The following is a description of a gene set: species: Mus musculus from publication Chen Y, Wang X (PMID 31504780) Mouse Gene Set: MIR_3102_5P Genes predicted to be targets of miRBase v22 microRNA mmu_miR_3102_5p in miRDB v6.0 with MirTarget v4 prediction scores > 80 (high confidence targets)., and this is the list of marker genes: Heph, Car7, Tmpo, Erv3, Frmd7, Tcf12, Slc2a1, Tcte2, Rbm39, Camta1, Hrh4, C130050O18Rik, Dnajb13, Tmem132c, Creb3l1, Nucb2, Pcbp2, Dlg2, Cyp2c38, Nufip2, Tanc2, Grk5, Gfpt1, Zfp74, Pax9, Fgf7, Slc22a23, Prxl2c, Slc9a7, Samhd1, Gpr137, Ric3, Hmgb2, Dock3 (NCBI Gene Id 638531), Ap1g1, Ttbk2, 1700012B07Rik